The following is a description of a gene set: Human Gene Set: RAMASWAMY_METASTASIS_DN Down-regulated genes in metastatic vs primary solid tumors. from publication Ramaswamy S, Ross KN, Lander ES, Golub TR (PMID 12469122) studied in species Homo sapiens Metastasis is the principal event leading to death in individuals with cancer, yet its molecular basis is poorly understood. To explore the molecular differences between human primary tumors and metastases, we compared the gene-expression profiles of adenocarcinoma metastases of multiple tumor types to unmatched primary adenocarcinomas. We found a gene-expression signature that distinguished primary from metastatic adenocarcinomas. More notably, we found that a subset of primary tumors resembled metastatic tumors with respect to this gene-expression signature. We confirmed this finding by applying the expression signature to data on 279 primary solid tumors of diverse types. We found that solid tumors carrying the gene-expression signature were most likely to be associated with metastasis and poor clinical outcome (P < 0.03). These results suggest that the metastatic potential of human tumors is encoded in the bulk of a primary tumor, thus challenging the notion that metastases arise from rare cells within a primary tumor that have the ability to metastasize., and this is the list of marker genes: F10, ACTG2, STAC, MAOB, PDE6A, AGRN, ZNF646, SLC10A3, MIR3648-1, NR2F2, ASPA, TAL1, MYL2, RORB, MAPRE3, ZNF148, GP1BA, FXN, PCDH11X, ABLIM1, RNASE4, PGK1, NR4A1, INPP5E, CNN1, NOS2, RUNX1, REL (REL proto-oncogene, NF-kB subunit), VAPB, ACADSB, MT3, CHRNA5, MYH11, CPN1, HNRNPF, P2RX1, PBX2, PLP1, MAP1B, GREM1 (NCBI Gene Id 7947), SPA17, MYLK, CPM, ZNF212, NCAPH, FCAR, JMJD1C, RBM5, KCNAB1, ROR1, PRSS53, PTN, CA12, RANBP3, PRKG2, MOS, RAB30, DLG3, HLA-DPB1